The following is a description of a gene set: RAS-like proteins are small GTP binding proteins characterized structurally by 5 G boxes that are involved in nucleotide binding and hydrolysis. RAS-like proteins are typically active when bound to GTP and inactive when bound to GDP. Conversion between the two states is mediated by effector proteins: among others, GTPase activating proteins (GAPs) enable hydrolysis of bound GTP to form GDP, which remains bound, and guanine nucleotide exchange factors (GEFs) enable exchange of bound GDP for free GTP (intracellular GTP concentrations are typically an order of magnitude higher than GDP concentrations).<br><br>The human genome includes over 150 members of the RAS superfamily grouped into five main subfamilies: RAS, RHO, ARF, RAB and RAN. These small GTPases affect a wide range of critical processes including gene expression, signal transduction, cell morphology, vesicle and nuclear trafficking, cellular proliferation and motility, among others.<br><br>The RHO family of GTPases is large and diverse, with many of its members considered to be master regulators of actin cytoskeleton, involved in the regulation of cellular processes that depend on dynamic reorganization of the cytoskeleton, including cell migration, cell adhesion, cell division, establishment of cellular polarity and intracellular transport.<br><br>MIRO proteins and RHOBTB3 protein, sometimes called atypical RHO proteins, show a high degree of overall sequence similarity to members of the five RAS-like subfamilies but diverge in their functions enough to constitute two separate subfamilies. MIRO proteins have intrinsically high GTPase activity and do not require GTPase activator proteins. They play an important role mitochondrial biogenesis, maintenance and organization. The GTPase domain of RHOBTB3 is divergent from other Ras like superfamily members and displays ATPase activity. RHOBTB3 is involved in CUL3 dependent protein ubiquitination, retrograde transport from endosomes to the Golgi apparatus, regulation of the cell cycle and in modulating the adaptive response to hypoxia. part of: Signal Transduction species: Homo sapiens Reactome Pathway: Signaling by Rho GTPases, Miro GTPases and RHOBTB3, and this is the list of marker genes: ABI2, BAIAP2, RBBP6, RAC3, MYL9, WASF1, DOCK10, TUBB4A, H2AC6, CENPE, RHOQ, ADD3, ARHGAP11A, PTK2B, DLG5, SYDE2, SAMM50, SPDL1, PLEKHG1 (NCBI Gene Id 57480), CKB, KCTD3, CKAP5, CAV1, MYLK, ITSN1, PPP1R12B, ALS2, MFN1, SKA2, CDC42EP2, YWHAB, FRS2, DYNLL2, GIT2, MYL12B, ARPC4, LEMD3, CLTC, RHOC, MOSPD2, H2BC21, CENPQ, MIS12, NCF4, SHKBP1, CSK, PARD6A, MCF2, NDC80, NCKAP1L, DST, DEPDC1B, SLC1A5, KDM1A, ARHGEF1, CCT6A, OPHN1 (oligophrenin 1), PRC1, NOXA1, TMPO, ARHGEF6, LMAN1, ARHGAP11B, SHMT2, OBSCN, PPP2CA, SENP1, CENPI, ARHGAP17, PLEKHG4, NCF1, RTKN, PAK2, FRS3, GJA1, NSL1, C1QBP, H2BC3, NUP133, DEF6, FARP1, MAD1L1, KLC4, CHN1, EMD, KIF5A, GOLGA3, SRC, CENPO, CYBA, CENPF, ARHGEF3, ARHGDIB, PKN3, PFN2, DOCK1, INCENP, TFRC, MAPK14, BCR, CENPT, H2BC13, H2AC14, SCFD1, IQGAP1, TUBA8, ARHGAP32, ARHGAP9, LETM1, TAOK3, SRF, ALDH3A2, KIF2C, TRA2B, H2BC9, BAIAP2L2, KIF2A, ARHGAP30, TWF1, FLOT1, RAB9A, CALM1, NET1, SRGAP2, ARHGEF7, VANGL2, RALBP1, LCK, DOCK5 (NCBI Gene Id 80005), HSP90AB1, FLOT2, PREX2, H2BC12L, TUBA1A, CFL1 (cofilin 1), H3-3A, AR, KIF14, DYNC1LI2, ARHGEF18, TUBAL3, RBMX, BUB3, VHL, CDC37, TUBB2B, SNAP23, FGD1, MYO19, CDC42, WASL, EMC3, DOCK2, GOPC, LBR, UBXN11, NCK2, WIPF3, PRKCZ, TRIP10, NOX3, ARHGEF2 (Rho/Rac guanine nucleotide exchange factor 2), CHN2, LIN7B, BUB1B, ACTR3, NF2, ARL13B, HINT2, TUBA3C, SOS1, IQGAP3, ARHGEF39, ARHGAP5, ARHGAP18, MAPK3, YKT6, RHOBTB2, FGD5 (FYVE, RhoGEF and PH domain containing 5), ARMCX3, SLITRK3, ARFGAP3, H2BC14, FGD3, KDM4C, PHIP, RHOT1, NOXO1, DIAPH3, POTEE, PTPN13 (protein tyrosine phosphatase non-receptor type 13), PCDH7, SPC25, TNFAIP1, STK10 (NCBI Gene Id 729035), RALGAPA1, CDH1, CCT7, ARHGAP40, PRKCD, DAAM1, ARHGAP35, KIDINS220, FLNA, ARHGAP25, ARHGAP31, PPP2R1A, GNA13, H2BC4, IL32, RAP1GDS1, NIPSNAP2, STOM, NDUFA5, ERCC6L, ROCK2, FNBP1L, DIAPH2, COPS2, ARPC1A, PLK1, CTNNB1, DNMBP, PFN1, KALRN, S100A8, FAM135A, CDC42EP1, KNTC1, PPP1CB, PPP2R5E, ACTG1 (NCBI Gene Id 71), FAM13B, EFHD2, PPP2R5B, RHOJ, MAPK1, AKAP13, PIK3R1, PIN1, VAPB, HSP90AA1, WIPF2, PPP1R14A, ARHGEF28, LAMTOR1, DLC1, VAV1, DYNC1LI1, KLC3, AHCTF1, NCKAP1, KLC2, CDC42EP4, ARHGAP29, NUP85, TEX2, H3C15, TUBA4A, LIMK2, ARHGDIA, ZW10, ARHGAP8, ARAP1, PIK3R4, COPS4, DOCK4, H4C1, ATP6AP1, PAK5, FARP2, KLC1, PAK6 (p21 (RAC1) activated kinase 6), RHOU, TAGAP, CDC25C, CDCA8, H2AX, ARHGAP27, RHOB, SPATA13, H2AC18, STIP1, CCNE1, CDC42BPA, MACO1, TUBA1C, NCK1, CIT, SEH1L, TMOD3, CENPM, ARHGEF17, CTTN, ABCD3, BIRC5, CENPL, HGS, STAM (NCBI Gene Id 8027), PEAK1, MYL6, ABL1, SFN, MSI2, ABR, NUP98 (nucleoporin 98 and 96 precursor), PLEKHG3, MTX1, STARD13, VRK2, PREX1 (NCBI Gene Id 57580), CLASP1, TUBB3, ARHGEF9, USP9X, RASAL2, DYNC1I1, SLITRK5, PAFAH1B1 (NCBI Gene Id 5048), TXNL1, WIPF1, H3C1 (NCBI Gene Id 8350), RHOD, ROPN1, SH3RF1, CAVIN1, ABL2, SYDE1, YWHAZ, KCTD13, CKAP4, SCRIB, MAD2L1, HTR7, SRRM1 (NCBI Gene Id 157635), KLK3, PLIN3, CCP110, RHOF, FMNL3, PKN1, CYFIP2, TMEM59, WDR6, DLG4, CDC42EP5, DBT, RANGAP1 (Ran GTPase activating protein 1), STARD8, ARHGAP20, STX5, ARHGEF12, RAB7A, GARRE1, CENPS, MAP3K11, WHAMM, NISCH, PAK4 (p21 (RAC1) activated kinase 4), RHOBTB3, ARHGEF16, DDX39B, OSBPL11, RAB9B, ARHGEF25, ANLN, DYNC1H1, S100A9, H2BC11 (NCBI Gene Id 8970), TUBB8B, CYFIP1, SOWAHC, PKP4, PRKCB, CENPN, MTMR1, CTNNA1, NDUFS3 (NCBI Gene Id 4722), MTR, LIMK1, MAPK11, PPP2CB, KIF18A, SKA1, TRAK1, PLEKHG6, PKN2, VAMP3 (vesicle associated membrane protein 3), RND1, MYH10, VIM, CENPU, CLASP2 (cytoplasmic linker associated protein 2), PRKCA, SLK, HMOX2, B9D2, ANKFY1, GPS1, RND3, MPP7, ARAP2, ARHGAP33, TUBB8, ARHGAP28, RPS27, H2AC7, MYO9B, DDRGK1, DOCK8, MCAM, GRB2, PLD2, DOCK9, ARHGAP19, RHOH, NCKIPSD, TUBB4B, MEN1, ESYT1, H2BC15, SH3PXD2A, LRRC1, PDE5A, RHOG, H2BC12, AKAP12, MYH11, HSPE1, PLXNB1, PRAG1, SGO1, TPM3, JAG1, ACBD5, YWHAG, FMNL2, DOCK11, SWAP70, KIF2B, SPTAN1, DVL2, BAIAP2L1, STAM2, H2BC17, MAPRE1 (microtubule associated protein RP/EB family member 1), ARHGEF4, KLK2, VAV2, RASGRF2, H2AC20, SH3BP1, NCOA2, PLEKHG5, NDEL1, ARFGAP2, BLTP3B, RAPGEF1, NUP107, ZWINT, ARHGEF26, BCAP31, PIK3R3, CCDC88A, TUBA3E, HNRNPC, IQGAP2, TJP2, ARHGAP15, ARHGAP1, ARHGAP21, CENPP, MRTFA, DIAPH1, CDC42SE2, PDPK1 (3-phosphoinositide dependent protein kinase 1), CDC42BPB, CDKN1B, DBN1, LRRC41, ARHGAP10, GIT1, PARD6B, TOR1AIP1, CDC42EP3, ARHGAP44, FAM91A1, TUBA1B, AMIGO2, TMEM87A, SCAI, SOS2, KNL1, ARPC2, MYH14, RAC2, PTK2, WDR11, CYBB, ARHGEF15, NUP37 (nucleoporin 37), ARHGAP4, ARPC3, ARAP3, AURKB, WAS, ANKLE2, WASF2, CENPH, MUC13, MYO9A, PLEKHG4B, RNF20, ACTN1 (actinin alpha 1), PIK3R2, VMA22, FNBP1, RCC2, FAM13A, RHOBTB1, RHPN1, ACTR2, TRAK2, MFN2, PIK3CA, ARHGAP22, TPM4, ECT2, ARHGAP26, RHOV, DSN1, ARHGEF10L, STMN2, SRGAP3, VANGL1, ACTB, VCP, DYNC1I2, ABI1, RACGAP1, ARHGAP42, ARHGEF5, ARHGAP12, H2BC26, EVL, PLXNA1, DSG2 (NCBI Gene Id 1829), ARHGAP39, NCF2, PAK1, H2AB1, H2BC5, EPHA2 (NCBI Gene Id 1969), OCRL, CCT2, STEAP3, ITGB3BP, ARHGEF19, ERBIN (NCBI Gene Id 55914), GFOD1, RHPN2, ITGB1, CEP97, RHOA, TUBA3D, DDX4, ARHGDIG, CAPZB, CFTR, ARHGAP6 (Rho GTPase activating protein 6), RAC1, PPP1CC, PLXND1, SEMA4F, UACA, DOCK3, SRGAP1, CPNE8, AAAS, WDR81, DVL1, NUDC, FAM83B, PAK3, DSG1 (NCBI Gene Id 1828), SPC24 (NCBI Gene Id 147841), KIF5B, FAF2, WASF3, STK38, CCDC187, PGRMC2, ARPC1B, RRAS2, SPTBN1, FGD2, CDC20, NHS, NDE1, PPP2R5A, TUBB2A, NGEF, YWHAE (tyrosine 3-monooxygenase/tryptophan 5-monooxygenase activation protein epsilon), STBD1, H2BC1, WDR91, BTK, PPP1R12A, BRK1, ARHGEF10, CENPK, PPP2R5D, DOCK6, DYNLL1, TAOK1, H2AJ, TRIO, ACTC1, ELMO2, PPP2R1B, TUBB1, PLD1, FERMT2, CENPA, NSFL1C, KTN1, ROCK1, H2AC4, NUF2, ARHGEF11, ZNF512B, ARHGAP24, FGD4, TUBB6, TAX1BP3, SGO2, SLC4A7, YWHAQ, NUP160, JUP, GRB7, ARPC5, VAV3, PLEKHG2, CLIP1, NOX1, XPO1, PICALM, ARHGEF40, ARHGAP45, CENPC, RHOT2, PIK3C3, BASP1, ZWILCH, TIAM2, MYH9, DOCK7, ARHGAP23, WWP2, PPP2R5C, ANKRD26, SPEN, CUL3, CPSF7, RANBP2, LMNB1, ZAP70, DSP, H2AZ2, FILIP1, EPSTI1, CPD, SEC13, FMNL1, PMF1, BUB1, MCF2L, YWHAH, GMIP, MYO6, RND2, ITSN2, FAM169A, TIAM1, DVL3, GOLGA8R, TUBA4B, NUP43